Given this list of marker genes OCA2, DOCK7, MAGEL2, NDN, SNRPN, here is a description of the gene set: Human Gene Set: HP_OCCIPITAL_CORTICAL_ATROPHY Occipital cortical atrophy studied in species Homo sapiens Atrophy of the occipital cortex.